The following is a description of a gene set: Mouse Gene Set: GOBP_POSITIVE_REGULATION_OF_CD8_POSITIVE_ALPHA_BETA_T_CELL_DIFFERENTIATION Any process that activates or increases the frequency, rate or extent of CD8-positive, alpha-beta T cell differentiation. studied in species Mus musculus, and this is the list of marker genes: Lilrb4a, Nckap1l (NCBI Gene Id 78813), Lilrb4b, Runx3, Runx1, Cbfb